Given this list of marker genes CD1D, RAE1 (ribonucleic acid export 1), KITLG, EEF2K, SUMO2P7, MSL2, DENND2B, CCKBR, PDE4B, TBC1D1, THAP7, DDX24, CLK1, STAT5A, BLOC1S1, RBM4B, POLG, ZPR1, RASGRP2, IRF9, POLG2, RPL37A, ANKIB1, GGT1, NDFIP2, SYNRG, EIF2AK2, PHF1, USP21, CXorf38, KIT, KCNH1, BANP, SLC25A25, WBP1, KLC4, CANT1, TRAPPC14, FGD3, DNAJB4, PIGN, RCVRN, KIAA0319L, FOXK1, TCN2, ST3GAL1, SPINK4, CD79B, PRPSAP2, ICAM2, PI4K2A, KLHL7, LGALSL, FBXW4, SLFN12, TMEM268, GCSAM, RPS15A, AZI2, SURF4 (NCBI Gene Id 6836), GREM2, DVL1, TEK, BCL6, CCR9, ZBTB20, INSM1, H2AC21, KIF3C, ACVR2A, SCEL, RPS27, CREBBP, MTFR1L, ACOT8, MAPK8IP3, BMP2K, MYL3, NEDD4L, BRWD3, AKIRIN1, KRT1, S1PR1, ASGR2, BPNT1, HGF, ERCC2, CLTB, ATAD2B, OSBPL5, DIAPH1, NECAP1, POMC, HCFC1R1, NCOA3, DNASE1L1, ZKSCAN1, TIMP2, SIAH1, MYOM2, CCDC117, ARSA, EXOC7, SH3GL1, PAPSS2, ALKBH5, DPEP3, EIF4H, ZNF292, SEC11C, B4GALT1 (beta-1,4-galactosyltransferase 1), USP34, ZNF622, TMEM115, RETREG2, RECQL, TRAFD1, PADI1, TRAF2, MAP1LC3A, GZMA (NCBI Gene Id 3001), CWC22, RAB33B, PKD1 (NCBI Gene Id 5310), MROH1, CAPN6, NCOA1, PRCC, MYL6, BTC, CXCR4, HOXA3, KLF2, HERPUD1, F9, BRAP, SLC39A4, SP4, MX1, TPT1, SGPP1, KLHL21, WNT11, PYGM, MCOLN2, F3, CNTRL, UBXN6, ABCG1, BSDC1, CMTM3, CYP2J2, USP2, CFH, C22orf39, ADGRG3, E2F5, AKAP7, VPS37B, ACKR3, RAB5B, PDIA4, SH2B3, DAO, GGPS1, GABBR1, ZDHHC5, PLEKHA5, PEA15, RC3H2, PMPCA, UBE2E3, TEC, PCSK7, WNT7B, TLE4, NR1D2, RBMS1, FRAT1, CPSF7, NR2C1, TSC1, RPL12, LHCGR, CTNNAL1, SERPINC1, SCAF8, IMPACT, TLR7, SPR, COQ10A, YJU2, NFE2L1, SNX13, C19orf48P, RECK, GDAP2, RPL22, RAB17, ZYG11B, here is a description of the gene set: from publication Agarwal P, Raghavan A, Nandiwada SL, Curtsinger JM, Bohjanen PR, Mueller DL, Mescher MF (PMID 19592655) Genes up-regulated in comparison of CD8 T cells at 0 h versus those at 72 h after treatment with trichostatin A (TSA). Differentiation of naive CD8 T cells into cytotoxic effector cells requires three distinct signals- antigen (signal 1), costimulation -B7-1 (signal 2) and cytokine, either interleukin-12 or interferon-a/b (signal 3). Interaction of naive CD8 T cells with antigen and B7-1 programs cell division and proliferation whereas the presence of cytokines- IL-12 or IFNa/b promote survival, differentiation and memory establishment. In the absence of signal 3, the cells interacting with antigen/B7-1 undergo tolerance induction. The objective of this study was to elucidate the mechanisms how the provision of signal 3 promotes differentiation and averts tolerance induction in CD8 T cells. Trichostatin A is a pharmacological agent that inhibits histone deacetylase activity, hence regulating chromatin structure and gene expression and differentiation in many cell types. Gene signature profiles of IL-12, IFNa/b and trichostatin A stimulated cells were compared to elucidate the molecular mechanisms of gene regulation. Oligonucleotide microarray analysis is carried out to determine the extent and molecular nature of the CD8 T cell differentiation program induced by IL-12 or IFNa/b in concert with antigen and B7-1 signal. Human Gene Set: GSE15930_NAIVE_VS_72H_IN_VITRO_STIM_TRICHOSTATINA_CD8_TCELL_UP studied in species Homo sapiens